The following is a description of a gene set: Any process that stops, prevents, or reduces the frequency, rate or extent of osteoclast differentiation. Human Gene Set: GOBP_NEGATIVE_REGULATION_OF_OSTEOCLAST_DIFFERENTIATION studied in species Homo sapiens, and this is the list of marker genes: LILRB3, CLDN18, GPR137, UBASH3B, FSTL3, GPR137B, GPR55, LILRB1, IAPP, NF1, FBXW7, LTF, LILRB4, CALCA, TOB2, INPP5D, TNFRSF11B (TNF receptor superfamily member 11b), TCTA, IL4, SFRP1, TMEM178A, CTNNB1, TLR4, FBN1, TNFAIP6, CCL3, ERFE, PIK3R1, LRRC17, ZNF675, PIAS3, MAFB, CARTPT (NCBI Gene Id 9607), TLR3